Given this list of marker genes E2F1, TREX1, ZNHIT1, PPM1D (NCBI Gene Id 8493), ZMPSTE24, SESN2, NOP53, MIF, PLK1 (polo like kinase 1), PML, STK33, EEF1E1, RPS6KA6, FOXO4, RHNO1, BRIP1, MRE11, EME2, BATF, FBXO4, PMAIP1, UFL1 (NCBI Gene Id 23376), MSX1, PTPN11, CCND1, GTSE1, ZNF830, E2F7, TTI2, TIPRL, CRY1, DGKZ, FEM1B, GIGYF2, FBXO6, BRSK1, MAPK12, CD44, ABRAXAS1, IER3, BCL3, DYRK1A, EIF2AK4, MUC1, MYO6, KDM1A, GADD45A, RFWD3, PPP1R10, ATM, TOPBP1, CD74, GRB2, COPS3, TP53, XPC, RPA2, RBM38, DDX5, MUS81, KAT5, EME1, RNASEH2B, PAXIP1, BLM (BLM RecQ like helicase), PLA2R1, USP10, DYRK3, CUL4A, SYF2, HINFP, CDK2, ATRX, CDKN1A, TAOK3 (NCBI Gene Id 51347), TRIM39, HUS1, CCAR2, RNF8, ACER2, NPM1, YJU2 (NCBI Gene Id 55702), BID, RAD9B, BRCA1, MDC1, PTTG1IP, CRADD (NCBI Gene Id 8738), PARP9, TAOK1, MSH2, CASP2, CDK1, TFAP4, TAOK2, SP100, TRIAP1, CDKN1B, MDM2 (NCBI Gene Id 84825), TELO2, NBN, ATR, UIMC1, PRAP1, H2AX, SPRED1, TWIST1, PYHIN1, WAC, TICRR, PIDD1, CDC5L, NEK11, PRPF19, ING4, NDUFS6, RAD51, ABL1, WNT1, BARD1, CDKN2A, PSMD10, BRCC3, CDK5RAP3, ANKRD1, SDE2, HIPK2, CLOCK, MBTPS1, RAD17, SNAI1, GNB1L, LYN, CEP63, USP28, KMT5A, ATF2, MAPK14, TP53BP1, BABAM2, ETAA1, PLK3, DTX3L, FANCD2, PPP2R5C, CHEK1, CLSPN, INTS7, DONSON, RPA4, HUS1B, ATAD5, SOX4, MARCHF7, WDR76, RPS27L, TIPIN, FZR1, ATRIP, TTI1, SIRT1, ERCC6, MAP2K6, DTL, RAD1, MRNIP, MDM4, FOXO3, BABAM1, MAP3K20, SMYD2, CASP9, SPRED2, FOXN3, FOXM1, CDC14B, PLK2, RAD9A, HIC1, BRCA2, FBXO31, CHEK2, SNAI2, BRD4, ZNF385A, MAPK3, NDRG1, PRKDC, MBTPS2, MAD2L2, RINT1, STK38, DOT1L, RPL26, GML, here is a description of the gene set: Human Gene Set: GOBP_SIGNAL_TRANSDUCTION_IN_RESPONSE_TO_DNA_DAMAGE A cascade of processes induced by the detection of DNA damage within a cell. studied in species Homo sapiens